The following is a description of a gene set: studied in species Mus musculus Zmpste24 (also called FACE-1) is a metalloproteinase involved in the maturation of lamin A (Lmna), an essential component of the nuclear envelope. Both Zmpste24- and Lmna-deficient mice exhibit profound nuclear architecture abnormalities and multiple histopathological defects that phenocopy an accelerated ageing process. Similarly, diverse human progeroid syndromes are caused by mutations in ZMPSTE24 or LMNA genes. To elucidate the molecular mechanisms underlying these devastating diseases, we have analysed the transcriptional alterations occurring in tissues from Zmpste24-deficient mice. We demonstrate that Zmpste24 deficiency elicits a stress signalling pathway that is evidenced by a marked upregulation of p53 target genes, and accompanied by a senescence phenotype at the cellular level and accelerated ageing at the organismal level. These phenotypes are largely rescued in Zmpste24-/-Lmna+/- mice and partially reversed in Zmpste24-/-p53-/- mice. These findings provide evidence for the existence of a checkpoint response activated by the nuclear abnormalities caused by prelamin A accumulation, and support the concept that hyperactivation of the tumour suppressor p53 may cause accelerated ageing. Human Gene Set: VARELA_ZMPSTE24_TARGETS_UP from publication Varela I, Cadiñanos J, Pendás AM, Gutiérrez-Fernández A, Folgueras AR, Sánchez LM, Zhou Z, Rodríguez FJ, Stewart CL, Vega JA, Tryggvason K, Freije JM, López-Otín C (PMID 16079796) Top genes up-regulated in liver tissue from mice with knockout of ZMPSTE24., and this is the list of marker genes: RGS16, CSNK1D, CYP26A1, NCDN, ZBTB16, CRCP, CUX2, SLC20A1, BAIAP2, SNORD30, ADARB1, TNFRSF1B, MAPKAPK2, TSR1, CDKN1A, CIRBP, BTG2, SUSD6, ATF4, ZFP36L2, H1-2, GADD45G, TXNIP, SNHG6, ATF3, GADD45B, BCL2L1, DDIT4, SLC25A51, SESN1, PI4K2A, PIM3, MKNK2, MYC, NR1D1, C15orf39, CYP2C19, ERF, CD14, TIPRL, GADD45A, LEPR, KLF3, BTG3